Given this list of marker genes SDHD, SDHC, SDHB, GSTO1, AS3MT, SDHA, here is a description of the gene set: studied in species Homo sapiens Human Gene Set: KEGG_MEDICUS_PATHOGEN_ARSENIC_TO_ELECTRON_TRANSFER_IN_COMPLEX_II Arsenic to electron transfer in complex II. Pathway ID: N01392. Pathway type: Pathogen. Pathway class: nt06252 Mitochondrial ROS formation. Pathway Definition from KEGG: As -- AS3MT >> GSTO1 -> MMA -| CxII